The following is a description of a gene set: species: Mus musculus Reactome Pathway: Calmodulin induced events electronically inferred by orthology from the curated human pathway part of: CaM pathway This event has been computationally inferred from an event that has been demonstrated in another species.<p>The inference is based on the homology mapping from PANTHER. Briefly, reactions for which all involved PhysicalEntities (in input, output and catalyst) have a mapped orthologue/paralogue (for complexes at least 75% of components must have a mapping) are inferred to the other species., and this is the list of marker genes: Adcy5, Calm1, Prkaca, Pde1c, Camkk1, Adcy8, Prkar1b, Prkacb, Prkca, Camkk2, Prkar2b, Prkcg, Pde1b, Adcy7